The following is a description of a gene set: from publication Széles L, Keresztes G, Töröcsik D, Balajthy Z, Krenács L, Póliska S, Steinmeyer A, Zuegel U, Pruenster M, Rot A, Nagy L (PMID 19201860) Human Gene Set: GSE13762_CTRL_VS_125_VITAMIND_DAY5_DC_DN We have carried out global gene expression analysis to clarify the interrelationship between 1,25-dihydroxyvitamin D3 and differentiation-driven gene expression patterns in developing human monocyte-derived dendritic cells. Monocytes were treated with 10 nM 1,25-dihydroxyvitamin D3 or vehicle 14 hours after plating for 12 hours or 5 days. Monocytes, differentiating dendritic cells (+/-1,25-dihydroxyvitamin D3 for 12 hours) and immature dendritic cells (+/-1,25-dihydroxyvitamin D3 for 5 days) were harvested. This design allows one to identify genes regulated by differentiation and/or 1,25-dihydroxyvitamin D3 in human monocyte-derived dendritic cells. Genes down-regulated in dendritic cells (5 days): control versus 25-hydroxyvitamin D3. species: Homo sapiens, and this is the list of marker genes: DLEU2, MIR204, ITGA5, ITPKB, FGF11, RAB20, AMZ2, TRPM5, DBN1, NHLRC1, TKTL1, ARHGAP39, ZSCAN10, MLYCD, KRTAP4-7, DISP2, MEOX1, MRPL11, DCST2, MMD2, ARHGEF4, CDC42EP2, MBP, THAP3, GRB7, TMEFF1, KCNK13, QPRT, CIMAP1D, BCR, KLHL23, GLP2R, IRX3, SLC35F1, IFNL2, FOXD4, PANX1, ZBTB3 (NCBI Gene Id 79842), RERG, EEF1D, ZDHHC12, TMEM69, WDR17, PGAM5, UPK3B, CILP, PRDM16, STIM1, GSTT4, SALL3, LARGE2, CNR2, CD52, TSKS, SOX5, PDK2, GRM4, PLAAT3, FHIT, CLEC1B, IGDCC4, PXMP4, POLR1D, PTPN18, KCNK1 (NCBI Gene Id 3775), CAPN9, SERPINB5, MESP1, TIMM10, NHSL3, PDPK1, EGFL6, NACA, SNTN, ATP2B2, PTPN6, S100A16, USE1, GUCA2B, GABRE, HOXC10, MIER2, LCE1E, CLTA, PHLDB1, GATA4, RGR, BDH1, ABHD14B, ACSM4, RNF148 (NCBI Gene Id 378925), KLHL31, IFNA5, SULT1C2, ADAMTS4, RPL18, ADRB1, NGRN, HMGA1, TRH, NCCRP1, GFRA4, SYT8, WSCD2, TMEM53, CTDSP1 (CTD small phosphatase 1), VSIG8, ST7L, WDCP, GNS, VRK3, SBK1, MARCHF11, CD36, GTPBP3, RNASE1, REM1, WDR31, ALX3, MAPK8IP2, FAM169A, ZPBP2, POMGNT2, CALR3, FBXO4, SCGB2A2, CXCL14, FGFR3 (NCBI Gene Id 55546), RARRES1, P2RX3, KALRN, SPHK2, DDX59, IL1A